The following is a description of a gene set: Human Gene Set: GOBP_NEGATIVE_REGULATION_OF_CALCIUM_ION_DEPENDENT_EXOCYTOSIS Any process that stops, prevents, or reduces the frequency, rate or extent of calcium ion-dependent exocytosis. species: Homo sapiens, and this is the list of marker genes: SYT4, CDK5, RAP1B, STXBP3, GNAI2, CBARP, ADRA2A, REST, NOTCH1